The following is a description of a gene set: Human Gene Set: GSE17721_0.5H_VS_12H_PAM3CSK4_BMDC_UP from publication Amit I, Garber M, Chevrier N, Leite AP, Donner Y, Eisenhaure T, Guttman M, Grenier JK, Li W, Zuk O, Schubert LA, Birditt B, Shay T, Goren A, Zhang X, Smith Z, Deering R, McDonald RC, Cabili M, Bernstein BE, Rinn JL, Meissner A, Root DE, Hacohen N, Regev A (PMID 19729616) studied in species Homo sapiens Genes up-regulated in comparison of dendritic cells (DC) stimulated with Pam3Csk4 (TLR1/2 agonist) at 0.5 h versus those stimulated at 12 h. mouse primary BMDCs were stimulated with tlr ligands and gene expression changes were profiled on Affymetrix arrays, and this is the list of marker genes: HELB, SDHC, CDH1, CLEC4A, RPP40, PNPLA7, POLR2F (NCBI Gene Id 5435), KLF13, FAM13B, NFIA, TEP1, PRDX2, ATP5IF1 (NCBI Gene Id 93974), PXMP4, MLF2, PAPSS2, MAP2K3, DALRD3, SERPINB1, ALDH18A1, H2AZ1, UBAC1, ZNF704, TNS1, SASH3, CDC37, UQCR11, DNAJC3, BARHL1, ZDHHC7, EID1, EEF1B2, ABHD17A, SPNS2, SLC7A4, ACBD6, HINT2, GGCX, DCPS, RAB3IL1, PRR15 (NCBI Gene Id 222171), EHD4, LAPTM4B, FLT1, MIIP, MYO9B, HNRNPUL1, KDM2B, ZBTB2, IGBP1, TIAM1, RPS6KA4, PSRC1, LIMK1, IL7R, RFC2, FERMT3, EGR2, RETREG1, PSME4, ZIM3, CD300C, RAG2, AXIN2, ELP3, TIMP2, IRF2 (NCBI Gene Id 3660), SKA2, GTF2F1, IBSP, WDR45 (NCBI Gene Id 11152), TNFRSF9, MYCL, FAM76A, RPL22, IL17RC, INTS7, PALD1, ERCC6L, TEAD2, MUSTN1, HBB, DECR1, PKIB, KLF6, HIBADH, NR2E3, OSBPL2, TXNDC16, DNAJC5, MXI1, TOB1, INPP4A (inositol polyphosphate-4-phosphatase type I A), ARAF, ABCG1, NES, BDH1, RECQL, DPYSL5, DMPK, CLEC10A, SLC7A5, IRS2, SLC9A8, SMIM8, FFAR2, AEN, MGMT, ACSF2, TXNDC9, TMEM131L, C8orf33, RPIA, NAT8, LRRC18 (leucine rich repeat containing 18), CD99, ZNF362, COX15, PTPN18, PDLIM5, DGLUCY, MAFB, KIAA0513, MICOS13, TLR4 (NCBI Gene Id 7099), TMEM141, NRDE2, MBD1, CENPK, TRPM5, ELOVL6, MTARC2, NBL1, RASA3, GTF3A, CASR, RANBP3, DOCK8, C1orf54, C1QB, TM7SF2, RGCC, IL16, LRRC56, GFI1B, IDH1, MICAL2, AIMP1, MYO7A, NOL12, PER1, RAG1, CUX1, HNRNPF, TRIM11, ELK4, PRMT7, TALDO1, RNH1, PRAF2, SAAL1, GPRASP1, TGFBR2, S100A6 (NCBI Gene Id 6277), SDHAF1, ZFP36L1, GLRX3, MPND, ABHD8, CCNH, SPHK1, SRSF6, SPTBN1, HNRNPC (heterogeneous nuclear ribonucleoprotein C), FNBP1, SRM, DMRTB1, TH, EIF3F, EVI5, IFT172, C1D, GUCA1A, MMS19, AGGF1, STEAP3, BSCL2, MTHFD1, SLC25A3, SBF2, HAUS4, ARID5A, PRXL2A, OR51B4, NAF1, CYB561D2, KLF9, CCL2, TMEM205, TOPBP1